Given this list of marker genes TMEM165, LRRC27, C19orf38, ATP6V0D1, ATG4C, MYO1F, DNMT1, GPCPD1, EMC3, HAUS8, EXOC4, MED30, GRN, TMPO, CDIP1, TTC7A (tetratricopeptide repeat domain 7A), PCTP, FCRL1, RETREG1, SYNPO2, PACS2 (phosphofurin acidic cluster sorting protein 2), ZC3H6 (zinc finger CCCH-type containing 6), STK38, WDSUB1, HTR2B, CTSD, MINDY2, TMEM144, PACRG, RASSF8, LAT2, PTPRA, TCTA, LIX1L, SIPA1L2, MFAP3L, OSER1, RASSF3, KAT2B, KIF13B, LYSMD3, CA9, TMCC3, EYA4, ITPR2, DHX40, NKIRAS2, CAB39L, PNPLA6, TMEM51, PRIM1, DEPTOR, TMEM127, CORO1B, CD302, CACUL1, CACFD1, CLIP1, HTATIP2, LHFPL2, SORL1, FYCO1, OARD1, SDHA, APC, RIT1, SMIM19, MBTPS2, C15orf61, TSPAN3, P2RX7, BPHL, NIBAN1, BLNK, PKP4, SENP8, MARVELD1, PLA2G7, PDXK, FAM234B, HAUS1, WWC2, GLT8D1, FAM32A, AK8, RNASE4, SLC16A10 (solute carrier family 16 member 10), COPG2, LRRC61, CPT1A, FAM83F, STARD8, CD28, MTCP1, TLR3, EPB41L3, CCNF, RWDD2A, GRB2, CELF2, CDKN1B, DSCC1, FAM241A, BBS2, NAT9, SQOR (sulfide quinone oxidoreductase), APLF, DTNBP1, SDF2, METTL21A (methyltransferase 21A, HSPA lysine), SPHK2, VPS26C, SMPDL3A, RAD54L, FTH1, RASA4, PPM1H, NMRAL1, ASPM, CEP83-DT, ZNF579, ZFYVE1, NR1H3, C1orf54, FIG4, RBL1, TNFAIP8L2, NCAPD2, BCAP31, AIFM2, TIFA, LRMDA, GALNT4, ZNF467, ANTXR2, ECHS1 (enoyl-CoA hydratase, short chain 1), TMEM14C, EEIG2, CD37, E2F7, LRP4, ABHD4, TUBGCP2, ZFYVE26, CLASP2, TMEM106A, RERE, YPEL3, MARCHF6, GPX4, MTMR10, H3C14, MFSD11, NEURL2, SIRT2, PURG, PGD, ACOT2, TOM1, LACC1, IFT70B, TCIRG1, NCOA2, CHMP1B, AAGAB, RAB6B, LY96, TBC1D31, PRUNE1, C9orf72, PFKFB3, SPG11, ITGB8, ABCC4, BCAS3, STARD3, NPL, MAN2C1, PHF3, SARAF (store-operated calcium entry associated regulatory factor), NACC2, HACL1, TMEM242, ERMARD, STAG2, PAQR7, PCMTD2, STARD9, FIGNL1, DYNLT1, ALDH2, RNF34, CTNS, GABPA, CYFIP2 (NCBI Gene Id 81032), BLVRA, SLC29A3, NBN, BAMBI, VPREB1, here is a description of the gene set: Genes up-regulated in bone marrow-derived dendritic cells: low dose of 1,3-beta-D-oligoglucan versus CSF2 and low dose of 1,3-beta-D-oligoglucan. A simultaneous engagement of different pathogen recognition receptors provides a tailor made adaptive immunity for an efficient defence against distinct pathogens. For example, cross talk of TLR and c-type lectin signalling effectively shapes distinct gene expression patterns by integrating the signals at the level of NF-κB. Here, we extend this principle to a strong synergism between the Dectin-1 agonist, curdlan, and an inflammatory growth factor, GM-CSF. Both together act in synergy in inducing a strong inflammatory signature which converts immature DCs to potent effector DCs. A variety of cytokines (IL-1β, IL-6, TNF-α, IL-2 and IL-12p70), costimulatory molecules (CD80, CD86, CD40 and CD70), chemokines (CxCl1, CxCl2, CxCl3, CCl12, CCl17) as well as receptors and molecules involved in fugal recognition and immunity such as Mincle, Dectin-1, Dectin-2 and Pentraxin 3 are strongly up-regulated in DC treated simultaneously with curdlan and GM-CSF. The synergistic effect of both stimuli resulted in strong IKBα phosphorylation, in its rapid degradation and in enhanced nuclear translocation of all NF-κB subunits. We further identified MAPK ERK, as one possible integration site of both signals, since its phosphorylation was clearly augmented when curdlan was co-applied with GM-CSF. Our data demonstrate that the immunomodulatory activity of curdlan requires an additional signal provided by GM-CSF to successfully initiate a robust β-glucan specific cytokine and chemokine response. The integration of both signals clearly prime and tailor a more effective innate and adaptive response against invading microbes and fungi. from publication Min L, Isa SA, Fam WN, Sze SK, Beretta O, Mortellaro A, Ruedl C (PMID 22250091) species: Homo sapiens Human Gene Set: GSE32986_CURDLAN_LOWDOSE_VS_GMCSF_AND_CURDLAN_LOWDOSE_STIM_DC_UP